The following is a description of a gene set: species: Mus musculus The cell cycle process in which a connection between chromatids assembles, indicating where an exchange of homologous segments has taken place by the crossing-over of non-sister chromatids. Mouse Gene Set: GOBP_CHIASMA_ASSEMBLY, and this is the list of marker genes: Rnf212, Msh5, Sycp3, Tex11, Sycp1, Ube2b, Rnf212b, Ccnb1ip1, Brip1